Given this list of marker genes Erbin, Il4ra, Kmt5b, Olfm4, Ubqln1, Rnf170, Pum1, H2-Q10, F2rl1, Ddx3x, Cd200, Cd300ld, Tfrc, Cmtm3, Cd1d2, Lair1 (leukocyte-associated Ig-like receptor 1), Src, Susd4, Zdhhc5, Zdhhc4, Rftn1, Colec11, Oas1e, Plscr1, Nlrc5, Gramd4 (NCBI Gene Id 223752), Gkn2, Cd300lf, H2-Aa, C8a, Cd59b, Ddrgk1, Tifab, Pla2g4a, Nlrp4b, Fosl1, Btk, Slc15a2, Grn, Gp6 (glycoprotein 6 platelet), Skint5, Ffar2, Ipo5, Ikbke, Arg2, Siglecg, Pms2, Lag3, Mettl3, Stoml2, H2-M3, Lypd11, H2-K1, Nod1, Bcl2, S100a9, Cd79b, H2-Eb1, Entpd7, H2-M2, Gbp2, Cr2, Rab29, Zbp1, Ido1, Dusp3, Tifa, Samhd1, Myo1f, Casp4 (caspase 4, apoptosis-related cysteine peptidase), Igha, Il27, Fosl2, Prkd1, Cd8b1, C1s2 (complement component 1, s subcomponent 2), Fcer2a, Ceacam1, Gdi1, Mapkapk3, Aurkb, Btnl1, Supt6, Lgals9, Rasgrp1, Cd44, Pdpk1, Bcl2a1d, H2-T15, Eif2b4, Polr3b, Mapk1, Cd47, Srebf1, Mul1, Gbp7, Nod2, Rnf125, Irf7, C5ar2, Btnl10, Trex1, Spns2, Cd37, Nlrx1, Inava, Pla2g2d, Brcc3, Zdhhc1, H2-M10.1, Trim62, Usp27x, Ifi205, Itk, Sla2, Ninj1, H2-M9, Letmd1, Pagr1a, Cyrib, Fcho1, Irf2, Tlr4, Nfkbiz, Stk11, Ulbp1, Fpr-rs7, Alpk1, Selenos, Ifih1, Hspa8, Fpr-rs3, Lilrb4a, Dpp4, Irgm2, Alox15, Znrf4, Cd4, Rps19, Tmigd3, C1qbp, Col3a1, Hrg, Lrch4, Ccdc134, Cfi, Cd36, Pram1, Adam8, Riok3, Ifi203-ps (NCBI Gene Id 100504287, interferon activated gene 203, pseudogene), Trim11, Sh2b2, Igtp, C1qc, Sphk2, Msh2, Otud5 (NCBI Gene Id 54644), Kit, Znrf1, Eif2b3, Treml4, Cd24a, Tnfsf13, Aplf, Chuk, Ppp6c (protein phosphatase 6, catalytic subunit), Zdhhc3, Cd96, Lime1, Cd40, Hlx, Skint7, Hsp90aa1, Ly96, Ap3b1 (NCBI Gene Id 97864), Smpdl3b, Pgc, Fcgr1, Il1b, C4bp, Tlr7, Crp, Cpt1a, Ddx60, Btn1a1 (butyrophilin, subfamily 1, member A1), Rasgrp4, Il21, H2-T24, Cptp, Otud4, Ifi204, Prkdc, Rbck1, Npy, Fut7, Ighg1, Kcnj8, Ins2, Sarm1, Tnfsf4, Fpr1, C9, Prkcq, Traf3, Ikbkg, Slc15a3, Cd38, Zdhhc18, Slc39a6, Lamp1 (NCBI Gene Id 234071), Laptm5, Slc46a2 (solute carrier family 46, member 2), Rnf115, Il20rb, Loxl3, Rnf34 (NCBI Gene Id 97276), Gm15441, Il6, Was, Tspan6, Themis, Nlrp1b, Bcar1, Pde4b, Fam3a, Ufl1, Ifi211, Usp29, Drd2, Phb2, Icosl, Gfi1, Tnip1, Cfhr4, Pten, Rtn4, Trim12a, Pla2g5, Stap1, Gbp3, Pvr, Serpinb1a, Parp14, Sash3, H2-Eb2, Syk, Traf3ip3, Pspc1, Prkd2, Clec12a, Anxa1, Klrd1, Bax (BCL2-associated X protein), Ticam2, Skint6, Nfkbil1, H2-Q2, Ywhaz, Akirin2, Elp6, Cr1l, Wnt5a, Cav1, Tgfb1, Lbp, Washc4, Gfer, Fpr-rs6, Mark4, Csk, Irf3, Bag6, Cd86 (NCBI Gene Id 677252), Ywhae, Cd55, Blk, Otop1 (NCBI Gene Id 231165), Btnl12, C5ar1, Cfp, Ifi207, Dhx9, Zbtb7b, Il17a, Ighe, Tyrobp, Ppp2r3c, Cd59a, Carmil2, Smcr8, Nop53, Nsd2, Serping1, Lrrc19, Sppl3, Vsir, Krt1, Wnk1, Cd300ld4, Trav7-2, H2-T23, Samsn1, Irak1, Usp18, Rgcc, Mir326, A1bg, Phpt1, Slamf6, Exosc6, Ptprj, Lck, Abl1, Trim32, Vav1, Appl1, Klrc1, Fadd, Raet1d, Trim30a, Pianp, Ager, Btla, Mfhas1, Cyld, Lacc1, Ubr2, Casp1, Klrc3, Cd300a, Trim31, Vsig4 (V-set and immunoglobulin domain containing 4), Ahr, Slc39a10, Usp46, Trim30c, Ereg, Irak3, Plcg1, Pglyrp3, Txk, Ivl, Xcl1, Usp12, H2-T13, Ctla4, H60b, Plscr2, H2-D1, Sh2d1b1, Eif2b2, Clec2d, Ifi208, Lrrfip2, Nos2, Colec12, Lat, Tnip3, Parp3, Zdhhc9, Cd14, Trafd1, Clec2i, Rc3h1, Colec10, S100a14, Plcl2, Ep300, Tomm70a, Ccr2, Atg12, Tyro3, Tarbp2, Znfx1, Sac3d1, Tlr3, Trem3, Lep, Casp8, Ccr6, Park7, Exosc3, Tlr12, Phb1, Lilra6, Dgkz, Card9, C4b, C6, Trat1, Lamp2, Traf6, Mir301, Lsm14a, N4bp1, Havcr2, H2-Ab1, Fcnb, Aars2, Ezr, Trp53bp1 (transformation related protein 53 binding protein 1), Atg5, Cd19, Ripk3, H2-M10.6, Il10, Oas1c, Clnk, Dennd1b, Foxj1, Azgp1, Trim12c, Ncr1, Ptafr, Zfp35, Serpinb9h, Lgals1, Arf6, Klrb1b, Nagk, Rapgef1, Skap1, Nr1d1, Clec4d, Ccl20, Oas1g, Fcer1g, H2-DMb2, Skint9, Cd79a, Ada, Tlr9, Tirap, Gpr108, Cacnb4, Ythdf3, Il12a, Dusp10, Fcmr (Fc fragment of IgM receptor), Trim6, Tnf, Socs5, Oscar, Fer, Gbp2b, Ptgs2os, Nr1h4, H2-M1, S100a8, Pum2, Pirb, H60c, Il7r, Lilra5, H2-Q1, Mr1, Pycard, Grb2, Itgam, Serpinb9f, Kat5, Hfe, Cd160, Pik3r1, Sqstm1, Traf2, Card10, Stat5b, C9orf72, Mad2l2, Lyplal1, Klk7, Apoe (NCBI Gene Id 11816), H2-DMa, Calhm6, Rbm14, Serpinb9e, Fcrlb, Mmp12, Gm12250, Abhd17a, Ifi214, P2rx7, Ltf, Skint3, Ythdf2, Trim56, Ctsg, Tarm1, Irak2, Hexim1, Evpl, Mbl1, Ddx39a, Fcer1a, Itgb2l, Gcsam, H2-Q7, Lrp8, Il12rb1, Peli1, Crk, Trim21, Itgb2, Eif2ak2, Fyb2, Inpp5d, Oas1b, Cfhr2, Ttll12, Nfam1, Atat1, Ncr3-ps, Nlrc3, Hspd1, Nfkb1, Klri2, Tyk2 (tyrosine kinase 2, NCBI Gene Id 54721), Lats1, Banf1, Pdcd1, Pawr (PRKC, apoptosis, WT1, regulator), Clec4n, Otulin, Cfd (complement factor D), Med1, Trpm4, C3, Smim30, Acod1, Il12b, Ighd, Blnk, Cd69, Bmx, Slc15a4 (solute carrier family 15, member 4), Nck1, Lpxn, Klrb1a, Parp1, Pira12, Prnp, Paxip1, Gpld1 (NCBI Gene Id 77224), Smad3, Skint8, Klrb1, Fcgr4, Usp15, Tlr1, Gpr17, Enpp3, Ctsh, Gata6, Tnfrsf1b, Serpinb9, Nckap1l, Ptpn22, Ms4a1, Sirt1, Tnfrsf14, Tgfb2, Fgl2 (fibrinogen-like protein 2), Card14, Clec12b, Gpx2, Cd28, Pvrig, Cblb, Irf1, Appl2, Ecm1, Tlr5, Ptpn2, Tlr8, Clec4e, Tespa1, Ccr7, Ascl2, Flot1, C1s1, Skint4, Ifng, Rigi, Slamf8, Blvra, C3ar1, Klrb1f, Usp50, Trim3, Zc3hav1 (NCBI Gene Id 78781), Cd300e, BC037156, Rnf144a, Cnot7, Oas1h, Vav3, Rsad2, H2-M10.3, Trim15, Fcgr2b, Dnaja3, Reg3g, Rnf135, Serpinb9g, Hmgb2, Rc3h2, Lyar, Themis2, Cnr1, Bcl10, Zdhhc12, Nploc4, Tnfsf13b, Polr3f, Cgas, Dtx4, Shld3, Gpx1 (NCBI Gene Id 14775), Kmt5c, Gps2, Cd300ld3, Skint1, Ifnl3, H2-Q4, Cd2ap, Serpinb9d, Mlh1, Btnl4, Xrcc6, Csnk1a1, Cfh, Btn2a2, Klk5, Stat2 (signal transducer and activator of transcription 2), Lat2, Prkaa1, Brd2, Opa1, Klri1, Fpr2, Cd81, Jak2, Cd177, Ccl19, Tlr11, Fgl1, Epg5, Lipa (lysosomal acid lipase A), Cd3e (NCBI Gene Id 12501), Scimp, Skint10, Btnl9, Kir3dl2, Fzd5, Ptpn6, Tap2, Nectin2, Pf4, Ankrd17, App, Sin3a, Zap70, Plekha1, Wdr41, Fcna, Trim25, Fgr, Klrk1 (killer cell lectin-like receptor subfamily K, member 1), Spsb3, Nlrp4a, Mef2c (NCBI Gene Id 71350), Aim2, Cfb, Il27ra, Esr1, Cfhr1, Ephb2, Ermap, Gimap3, Zc3h12a, Sh2d1a (SH2 domain containing 1A), Ifi203, Npy5r, Khdrbs1, Tkfc, Zp3r, Rps6ka3, Pigr, Sting1, Tap1, Kcnn4, Cep63, Abr (NCBI Gene Id 11357), H2-Ea, Smad7, Dusp22, Lrrc14, Ppp3cb, Tlr6, Il15, Nlrc4, Cactin, Pik3ap1, Stx7, Sh2d1b2, Pja2, Btnl2, Hmces, Cd80, Ap1g1, Stx4a, Themis3, Trem2, C1qb, Pglyrp1, Crkl, H2-Q6, H2-M10.2, Tec, Trim5, Tnip2, Mill1, Ubash3a, Nr1h3, Rbm47, Ncf1, Casp6, Tnfsf18, H2-Oa, Tlr2, Ighm, Sfn, Klrc2, Thy1, Cd226, Elane, Fbxl2, Ifnl2, Eif2b5, Psen1, Xrcc5, H2-DMb1, 6030468B19Rik, Mog, Nlrp1a, Trim30b, Ifi35 (interferon-induced protein 35), Mndal, Masp2, Ighg2c, Polr3c, B2m, Ube2k, Cd46, Ndfip1, D1Pas1, Brcc3dc, Oas1f, Skint11, Serpinb9c, Rela, Oas1a, Zp3, C4a, Pira2, Lypd10, Pkn1, Slamf1, Psen2 (NCBI Gene Id 98295), Stmp1 (short transmembrane mitochondrial protein 1), Nectin4, Nek7, H2-Ob (histocompatibility 2, O region beta locus), Nmi, Ptprs, Ogt (O-linked N-acetylglucosamine (GlcNAc) transferase (UDP-N-acetylglucosamine:polypeptide-N-acetylglucosaminyl transferase)), Cd300c2, Ppt1, Fyb1, Ecsit, Bpifb1, Tmem126a, Slc11a1, Dab2ip, Usp17le, Tnfrsf21, Fcgr3, Washc1, Clec7a, Gpr33, Gata3 (GATA binding protein 3), Cd300ld2, Hspa1b, Fyn, Cd55b, Pck1 (phosphoenolpyruvate carboxykinase 1, cytosolic), Xbp1, Il2, Pira13 (NCBI Gene Id 100041146), Mefv, Igsf1, Adar, Serpinb9b, Parp9, A2m, Sos1, Ccr1, Lyn, Il4, Clpb, Vav2, Il18r1, Cmklr1, Polr3g (NCBI Gene Id 67486), Gsdme, Vtcn1, Muc4, Cd276, Rap1a, Phf11a, Plcg2, Map3k7, Masp1, Btnl6, Irf4, Nlrp10, Oasl1, Myo1g, Cd274, Skint2, Mir181b-2, Il4i1, Stat5a, Ighg2b, Becn1, Inppl1, Ufd1, Irgm1 (NCBI Gene Id 15944), Dnase2a, Raet1e, Peli3, Cadm1, Gigyf2, Lgr4, Tab1, Shld2, Igf2, C7, Cd5l, Pqbp1, Tbx21, Tlr13, Usp38, Klhl22, Itpripl1, Eif2b1, Tax1bp1, H2-T3, C8g, Rif1, H2-T5, Sfpq, Cd22, Arg1, Card11, Wdfy1, Fbxo38, Kir3dl1, Ins1, Nfe2l2, 2410137M14Rik, Adcyap1, H2-M10.5, Slc22a13, Zcchc3, Il23r, Kars1, Ifi213, Fpr3, Lcp2, Ticam1, Rps3, H2-M11, Hras, Cd247, Jak3, Pglyrp2, Gbp5, C8b, Naglu, Unc93b1, Cd300c, Cacnb3, Usp9x, Mir181b-1, Ywhag, Bcr, Rab11fip2, Sec14l1, C1rl, Spi1, Il18, Cd74, Il18rap, Nfkbia, Cdc37, Nr4a3, Oas1d, Eif2ak4, Psma1, Crtam, Foxp1, Gpr31b (NCBI Gene Id 50539), H2-T22, Sppl2a (NCBI Gene Id 66552), Pnp, Pglyrp4, Cyba, Arid5a, Spn, Tnfaip3, Tasl, Fcrl5, Cd8a (NCBI Gene Id 669166), Nlrp4c, Il1r1, Lax1, Malt1, Nlrp4f, Rab7b, Tril, Elf1, Zfp683, Nfkbid, Nlrp6 (NLR family, pyrin domain containing 6), Mbl2, Pde4d, Hcst, Xiap, Arrb2 (arrestin, beta 2), Dcst1 (NCBI Gene Id 77772), Akt1, Isg15, Btrc, Mavs, Ppp2ca, Il33, Trim41, Polr3d, Ppl, Foxp3, Mapkapk2, Tnfrsf13c, Pparg, Prkch, Gpatch3, H2-M5, C2, Rnf185, Sppl2b, Matr3, Braf, Rnf31, Cd1d1, Nlrp3, Pik3r6, Hmgb1, Ighg3, Ptprd, Hcfc2, Ifi209, Prkce, Fpr-rs4, Eif4e2, Pcbp2 (poly(rC) binding protein 2), Il1rl1, C1ra, Smpdl3a, Il17f, C1rb, Clec4g, Nfatc2, Oas3, Clcf1, Sirt2, Ube2n, Psmb4 (proteasome (prosome, macropain) subunit, beta type 4), Prkcz (protein kinase C, zeta), Trim27, Cd40lg, Gimap5, Adcy7, Lta, Il23a (NCBI Gene Id 83430), Brd4, Ifnb1, Mif, Nono, C1qa, Hpx, Cd300lb, Ripk2, Pim1, Lgals3, Zbtb1, Trim30d, Rabgef1, Itch, Shld1, H2-M10.4, Rara, Dhx58, Kcnk13, Lats2, Tbk1, Slc19a1 (solute carrier family 19 (folate transporter), member 1), Klrb1c, Bcl6, Klhl6, Prkcb, Nras (neuroblastoma ras oncogene), Lilrb4b, Ptprc, Shb, Dhx33, Atad5, Myd88, Ifi206, Stat6, Hc, Nlrp4e, Klre1, Mkrn2, Mapk8, here is a description of the gene set: Mouse Gene Set: GOBP_REGULATION_OF_IMMUNE_RESPONSE Any process that modulates the frequency, rate or extent of the immune response, the immunological reaction of an organism to an immunogenic stimulus. studied in species Mus musculus